The following is a description of a gene set: Human Gene Set: HP_ABDOMINAL_OBESITY Abdominal obesity Excessive fat around the stomach and abdomen. studied in species Homo sapiens, and this is the list of marker genes: MAGEL2, HERC2, USP48, CDH23, CCDC28B, BBS1, ATRX, ARMC5, RNPC3, GNAS, ARL6, KDM1A, BLM, PWRN1, NKAP, NPAP1, PWAR1, AIP, ZPR1, BRAF, USP8, MKRN3, PRKAR1A, CUL4B, DYRK1B, LIPE, SNORD116-1, SIM1, SNORD115-1, TP53 (tumor protein p53), NR3C1, PDE11A